The following is a description of a gene set: Brief hallucinations that occur as you wake up in the morning, in a state that falls somewhere between dreaming and being fully awake. Hypnopompic hallucination species: Homo sapiens Human Gene Set: HP_HYPNOPOMPIC_HALLUCINATION, and this is the list of marker genes: CTSH, P2RY11 (purinergic receptor P2Y11), TNFSF4, HLA-DQB1, HCRT, MOG, ZNF365, HLA-DRB1